The following is a description of a gene set: Marker genes curated from the annotated cluster as represented in the Descartes Human Gene Expression During Development database. The gene expression program underlying the specification of human cell types is of fundamental interest. The study authors generated human cell atlases of gene expression and chromatin accessibility in fetal tissues. For gene expression, the study authors applied three-level combinatorial indexing to >110 samples representing 15 organs, ultimately profiling ~4 million single cells. The study authors leveraged the literature and other atlases to identify and annotate hundreds of cell types and subtypes, both within and across tissues. Our analyses focused on organ-specific specializations of broadly distributed cell types (such as blood, endothelial, and epithelial), sites of fetal erythropoiesis (which notably included the adrenal gland), and integration with mouse developmental atlases (such as conserved specification of blood cells). These data represent a rich resource for the exploration of in vivo human gene expression in diverse tissues and cell types. from publication Cao J, O'Day DR, Pliner HA, Kingsley PD, Deng M, Daza RM, Zager MA, Aldinger KA, Blecher-Gonen R, Zhang F, Spielmann M, Palis J, Doherty D, Steemers FJ, Glass IA, Trapnell C, Shendure J (PMID 33184181) studied in species Homo sapiens Human Gene Set: DESCARTES_MAIN_FETAL_UNIPOLAR_BRUSH_CELLS, and this is the list of marker genes: CNKSR2, RPH3A, ENSG00000259737, LMX1A, GRM1, LINC02032, CACNA2D1, CCDC175, EN2, EOMES, TRPC3, MORC2-AS1, GRIA2, VWC2, BARHL1, CACNA2D1-AS1, STXBP5L, ADCYAP1, UPP2, BLTP1, CNPY1, ZIC4, NDST4, FBXL21P, LINC02082, LEMD1-DT, ENSG00000243620, TRPC5, DPY19L3, NWD2, MPP3, HTR5A, KIRREL3, NAALADL2-AS2 (NCBI Gene Id 100874244), QKILA